Given this list of marker genes Phox2b, Kcnj16, F7, Trpa1 (transient receptor potential cation channel, subfamily A, member 1), Slc4a1, A2m, here is a description of the gene set: Mouse Gene Set: GOBP_RESPONSE_TO_CARBON_DIOXIDE Any process that results in a change in state or activity of a cell or an organism (in terms of movement, secretion, enzyme production, gene expression, etc.) as a result of a carbon dioxide (CO2) stimulus. studied in species Mus musculus